The following is a description of a gene set: This event has been computationally inferred from an event that has been demonstrated in another species.<p>The inference is based on the homology mapping from PANTHER. Briefly, reactions for which all involved PhysicalEntities (in input, output and catalyst) have a mapped orthologue/paralogue (for complexes at least 75% of components must have a mapping) are inferred to the other species. Reactome Pathway: MAPK3 (ERK1) activation part of: RAF-independent MAPK1/3 activation species: Mus musculus electronically inferred by orthology from the curated human pathway, and this is the list of marker genes: Mapk3, Il6, Map2k1, Tyk2, Cdk1, Il6ra